Given this list of marker genes MIR155, PPARA, NOS3, PTGS2, PDK1 (NCBI Gene Id 5163), MIR98, MIR675, H19, MIR1-1, PTGS1, MIR126, VEGFA, MIR32, MVD, MIR26B, NFKB1, MIR15B, ABCC4 (ATP binding cassette subfamily C member 4 (PEL blood group)), WNT1, here is a description of the gene set: Aspirin and miRNAs Human Gene Set: WP_ASPIRIN_AND_MIRNAS studied in species Homo sapiens